Given this list of marker genes Sorbs2, Atxn7l2 (ataxin 7-like 2), Btf3l4, Tmem161a, Notch4, Txndc12, Fbxl19, Zscan2, Etv6, Rrp15, Nlk, Chchd3 (NCBI Gene Id 73342), Sox5, Ing4, here is a description of the gene set: Genes containing one or more binding sites for (Sox5) in their promoter regions (TSS -1000,+100 bp) as identified by GTRD version 20.06 ChIP-seq harmonization. studied in species Mus musculus from publication Yevshin I, Sharipov R, Kolmykov S, Kondrakhin Y, Kolpakov F (PMID 30445619) Mouse Gene Set: SOX5_TARGET_GENES